The following is a description of a gene set: studied in species Homo sapiens Any process that activates or increases the frequency, rate or extent of keratinocyte apoptotic process. Human Gene Set: GOBP_POSITIVE_REGULATION_OF_KERATINOCYTE_APOPTOTIC_PROCESS, and this is the list of marker genes: SFRP4, SAV1, MIR4516, PIAS4, GSN